Given this list of marker genes Cfp, C1qc, Cpn2, Colec10 (NCBI Gene Id 239447), Cfd, Hc, C1ra, Vtn, C1qa, Fcnb, Serping1, Cd55, Cfi, Cr1l, Masp1, C5ar1, C5ar2, F2, Igll1, C8g, Mbl2, Colec11, C1s2, Cpn1, C3ar1, Fcna, Elane (elastase, neutrophil expressed), C1qb, C6, Cd19, C8a, Masp2, C2 (NCBI Gene Id 12263), C9, C3, Gzmm, Cd46, Cd81, C4b, here is a description of the gene set: This event has been computationally inferred from an event that has been demonstrated in another species.<p>The inference is based on the homology mapping from PANTHER. Briefly, reactions for which all involved PhysicalEntities (in input, output and catalyst) have a mapped orthologue/paralogue (for complexes at least 75% of components must have a mapping) are inferred to the other species. electronically inferred by orthology from the curated human pathway part of: Innate Immune System Reactome Pathway: Complement cascade studied in species Mus musculus